The following is a description of a gene set: Triggering of B cell receptors (BCR) induces a massive synthesis of NFATc1 in splenic B cells. By inactivating the Nfatc1 gene and re-expressing NFATc1 we show that NFATc1 levels are critical for the survival of splenic B cells upon BCR stimulation. NFATc1 ablation led to decreased BCR-induced Ca++ flux and proliferation of splenic B cells, increased apoptosis and suppressed germinal centre formation and immunoglobulin class switch by T cell-independent antigens. By controlling IL-10 synthesis in B cells, NFATc1 supported the proliferation and IL-2 synthesis of T cells in vitro and appeared to contribute to the mild clinical course of Experimental Autoimmune Encephalomyelitis in mice bearing NFATc1-/- B cells. These data indicate NFATc1 as a key factor controlling B cell function. Human Gene Set: GSE21063_WT_VS_NFATC1_KO_8H_ANTI_IGM_STIM_BCELL_DN Genes down-regulated in B lymphocytes stimulated by anti-IgM for 8h: wildtype versus NFATC1 knockout. species: Homo sapiens from publication Bhattacharyya S, Deb J, Patra AK, Thuy Pham DA, Chen W, Vaeth M, Berberich-Siebelt F, Klein-Hessling S, Lamperti ED, Reifenberg K, Jellusova J, Schweizer A, Nitschke L, Leich E, Rosenwald A, Brunner C, Engelmann S, Bommhardt U, Avots A, Müller MR, Kondo E, Serfling E (PMID 21464221), and this is the list of marker genes: PTGER2, ANKRD10, RBCK1, ZDHHC16, PITPNM2, MRPL24, TNFRSF12A, CCDC137, TNRC6B, RLIM, CLCN4, PIGK, ZNF280D, HGH1, NPRL3, RNF2, ADM, TJAP1, REST, GPM6B, HACD3, DMXL1, GALNT10, LDB1, VWA8, BLTP1 (bridge-like lipid transfer protein family member 1), WASHC1, HSD17B8, TOX, RNF123, RAPGEF4, MRPS30, SCAF4, ETNK1, TMA16, TCF12, ZNF740, GOSR2, ERGIC1, NEURL4, RPS29, CUX1, RBM5, MCOLN3, PSMB3, TRMT1, MPHOSPH8, PFKM, KHDRBS1, RPS4X, GK2, GOSR1, ZNF526, SLC44A2, FASTK (NCBI Gene Id 80166), UPF2, C19orf48P, ZNF329, RPL39, DHRS1, PMVK, PDCD7, STK10, USF2, ATP9B, CDK11B, ANKRD28, SPRY1, LRRC58, TPRA1, SYNPO, DIDO1, RPS23, TRAF2, PDE12, ZNF777, TNPO2, ZNF841, DHX30, PEX6, FAM76B, POU2F2, RPL13, C15orf39, FRAT2, KANSL2, TRAF1, TNNI2, DDX6, IDH3B, MDN1, ZFTRAF1, ICE1, MBTPS1, MFSD14A, RNF41, LAPTM5, CORO2A, PYGB, OGA, SORCS2, TMEM245, ZNF436 (zinc finger protein 436), HGFAC, CD86, SART1, LATS2, CNPPD1, FOXP1, LCLAT1, RCC2, AKAP8, RPL34, ZNF131, ZIK1, LYSMD1, ZMYND8, AP4B1, DDX54, SUFU, SLX9, TTC28, ATP9A, DENND4B, ARHGEF1, CBX6, ZBTB18, ZBTB7B, CDIP1, TOB2, KDM5B, CASC3, DPH2, TLK2, NAA30, LIPT1 (NCBI Gene Id 51601), ZNF142, ZNF22, RASSF5, UNK (NCBI Gene Id 85451), AOPEP, RSBN1 (round spermatid basic protein 1), NHSL1, PAPOLG, ZC3H10, SPTBN1 (NCBI Gene Id 91654), MCCC1, DBP, MIB2, NFX1, TSC1, ANGPTL2, UTP25, H2AC25, RHOT2, ETAA1, MRPL52, PCSK7, DCAF12, ZBTB14, GABRG1, PHKB, EEF2, PUM2, DGKZ, BAG6, ACO1, IKZF2, HLA-DOB, SLC44A1, AMBRA1, ELK4 (NCBI Gene Id 2005), SUPT6H, MAP3K1, UPF3B (NCBI Gene Id 65109), RMND5A, AMMECR1L, TSEN34, MAP2K7, NPEPL1, KMT2C, RASAL1, RPF2, SPRED2, NMD3, ARID4B, C6orf62, MSL1, RXRB, QSER1, GALM, RANBP9, RASSF8, KLC1, DNASE1L2 (deoxyribonuclease 1 like 2), CBFA2T2, DHRS4, ADORA2B (adenosine A2b receptor), CCNQ, ARHGAP5